Given this list of marker genes Hadha, here is a description of the gene set: This event has been computationally inferred from an event that has been demonstrated in another species.<p>The inference is based on the homology mapping from PANTHER. Briefly, reactions for which all involved PhysicalEntities (in input, output and catalyst) have a mapped orthologue/paralogue (for complexes at least 75% of components must have a mapping) are inferred to the other species. Reactome Pathway: Beta oxidation of hexanoyl-CoA to butanoyl-CoA part of: mitochondrial fatty acid beta-oxidation of saturated fatty acids electronically inferred by orthology from the curated human pathway species: Mus musculus